The following is a description of a gene set: part of: Metabolic disorders of biological oxidation enzymes species: Homo sapiens Reactome Pathway: Defective CYP1B1 causes Glaucoma Cytochrome P450 1B1 (CYP1B1) can oxidise a variety of structurally unrelated compounds, including steroids, fatty acids, and xenobiotics as well as activating a range of procarcinogens. A specific substrate is the female sex hormone estradiol-17beta (EST17b) which is 4-hydroxylated to 4-hydroxyestradiol-17beta 4OH-EST17b). Defects in CYP1B1 can cause glaucoma disorders such as Glaucoma 3, primary congenital, A (GLC3A; MIM:231300), Glaucoma, primary open angle (POAG; MIM:137760), Glaucoma 1, open angle, A (GLC1A; MIM:137750) and Peters anomaly (PAN; MIM:604229). These disorders cause a progressive optic neuropathy characterised by visual field defects that ultimately lead to irreversible blindness., and this is the list of marker genes: CYP1B1